The following is a description of a gene set: studied in species Mus musculus Any process that activates or increases the frequency, rate or extent of the chemical reactions and pathways involving catecholamine. Mouse Gene Set: GOBP_POSITIVE_REGULATION_OF_CATECHOLAMINE_METABOLIC_PROCESS, and this is the list of marker genes: Npy, Vps35, Park7, Hprt1, Epas1, Gpr37, Abat, Maob